The following is a description of a gene set: Part of the dendritic spine that connects the dendritic shaft to the head of the dendritic spine. Mouse Gene Set: GOCC_DENDRITIC_SPINE_NECK studied in species Mus musculus, and this is the list of marker genes: Sri, Gria2, Atp1a3, Ppp1r9b, Drd1, Grip1 (NCBI Gene Id 74053), Ppp1r1b, Fmr1, Ppp1r9a